The following is a description of a gene set: Mouse Gene Set: GOBP_REGULATION_OF_CELL_SHAPE Any process that modulates the surface configuration of a cell. studied in species Mus musculus, and this is the list of marker genes: Epb41, Epb42, Cdc42se1, Kdr, Fyn, Dlg1, Pdpn, Sema4a, Fam171a1, Anxa1, Eps8, Arhgap18, F11r (NCBI Gene Id 226655, F11 receptor), Zmpste24, Mark2, Plxnb2, Vil1, Cfl1, Gas2, Dapk3, Crk, Parvb, Palmd, Cdc42ep2, Hck, Cyfip1, Rhou, Septin7, Phip, Lpar1, Arap1, Parva, Fgr, Pxn, Ptk2b, Ccl12, Hpn, Fmnl2, Ypel4, Gna13, Gm14137, Slc26a5, Myh10, Ptn, Bambi, Epb41l2, Strip2, Hexb, Baiap2, Rhoj, Tbccd1, F2, Coro1a, Dlc1, S100a13, Fgd4, Rhog, Rac2, Ccl11, Icam1, Myh14, Ezr, Fermt2, Arhgap35, Bves, Sh3kbp1, Cdc42se2, Arhgdia, Cdc42ep4, Wasf3, Kit, Fgd1, Myo10 (NCBI Gene Id 52514), Fmnl3, Sema3e (NCBI Gene Id 330043), Cdc42ep3, Gna12 (guanine nucleotide binding protein, alpha 12), Spta1, Plxnb1, Wdpcp, Ccl24, Myh9, Ermn, Msn, Gas7, Plxnb3, Wdr1, Ccl7, Dmtn, Itga7, Fn1, Fblim1, Prpf40a, Pakap, Myl12b, Shroom3, Csf1r, Rdx, Myl12a, Il6, Sprr1b, Fmnl1, Kif3a (kinesin family member 3A), Plxnc1, Dnmbp, Plxnd1, Palm, Brwd3, Limd1, Rhobtb1, Ccl3, Arhgef18, Mkln1, Nherf1, Vegfa, Diaph1, Lst1, Syne3, Coch, Cfdp1, Rac3 (Rac family small GTPase 3), Brwd1, Tpm1, Aldoa, Rhoq, Epb41l3, Palm3, Cfap410, Ptk2, Taok2, Cdc42ep1, Rhobtb2, S100b, Fes, Anxa7, P2ry1, Sprr2a1, Cdc42ep5, Sema4d, Plekho1, Prag1, Arhgap15, Parvg, Nf2, Rac1